Given this list of marker genes MICALL2, WASH6P, PLA2G4E, PTPN23, NSG1, ACAP2, WASH3P, MICALL1, VPS51, LMTK2, EPS15, ARHGAP1, SORL1, ATP6AP1, VPS39, VPS26C, CMTM6, SCRIB, RAB8B, EIPR1, SNX4, RAB17, VPS29, SNX30, ACTN2, SNX31, DENND1A, SNX12, RAB11B, ARHGAP8, ARL4C, HGS, SNX3, GRIP2, RAB8A, ATP9A, GGA3, STX6, WASHC2C, BLTP1, GRIP1, DENND1B, VPS50, DENND1C, VPS35, EHD3, RAB11FIP4, VAMP4, AKAP5, EHD4, WASHC1, TRARG1, MTMR4, SNF8, RAB11FIP3, STX12, INPP5F, NDRG4, ZDHHC2, SNX17, VPS13B, ANKRD50, ENTR1, SNX7, EHD1, RAB12, VPS35L, STX16, LRRC7, ANKRD27, RAB7A, SNX27, ARHGAP44, EHD2, CCDC93, VPS52, GRIPAP1, CCDC22, VPS53, RAB13, EPG5, VTI1A, BVES (NCBI Gene Id 11149), RAB35, SCARB2, PLA2G3, RAB14, RAB11A, WIPF3, COMMD1, ARF6, VPS26A, here is a description of the gene set: Human Gene Set: GOBP_ENDOCYTIC_RECYCLING The directed movement of membrane-bounded vesicles from endosomes back to the plasma membrane, a trafficking pathway that promotes the recycling of internalized transmembrane proteins. species: Homo sapiens